The following is a description of a gene set: species: Mus musculus Genes predicted to be targets of miRBase v22 microRNA mmu_miR_489_5p in miRDB v6.0 with MirTarget v4 prediction scores > 80 (high confidence targets). Mouse Gene Set: MIR_489_5P from publication Chen Y, Wang X (PMID 31504780), and this is the list of marker genes: Eif3a, Nfe2l2, Kcnma1, Mysm1, Gm5142, Ereg, Mpp3, Rnf139 (NCBI Gene Id 75841), Pi15, Hnf4g (hepatocyte nuclear factor 4, gamma), Ggps1, Heca, Lamtor5, Dyrk3, Ror1, Lox, Twist1, Gnat1, Prex1, Fbxo30, Saraf, Dgkb, Slfn14, Fgfr2, Hoxd1, Rfx4, Slc30a1, Pls1, Ano4, Slc25a36, Mmp27, Cetn4, Pcdh20 (NCBI Gene Id 219257), Chd1, Bhlhe40, Snap29, Rora, Wfdc12, Fbn2, Cnot2, Mknk1, Pitx2, Fhl4, Gpr158, Bpifc, Atg10, Gask1b, Fezf2, Tent2, Lratd2, Prkg1, Nkx3-1, Igf2bp3, 9230112D13Rik, Tiprl, Stk17b, Wwp1, Cul2, Mindy2, Cadm2, Pax3, Cep120, Grm5, Mapk1, Cep57l1, Cd163 (CD163 antigen), Eif5a2, Adnp, Chsy3, 1500009L16Rik, Gng12, Cebpg, Kcnj6, Spred1, Tmem123, Nap1l1, Naaa, Sorbs2, Rnf113a2, Rfxank, Nfkbie, Ret, Pdgfra, Pik3r1, Mier3, Zfp810, Zbtb1, Pla2g4a, Rgmb, Ociad2, 1700028K03Rik, Mtmr9 (NCBI Gene Id 210376), Itpr1, Dda1, Rasef, Cxcl16, Pde8b, Idua, Bpnt2, Tbcel, Cxcl12, Meox2, Thap12, Ptgr2, Psg16, Bmi1, Radil, Ankrd46, Ciao2a, Opa1 (OPA1, mitochondrial dynamin like GTPase, NCBI Gene Id 74143), Ces2e